The following is a description of a gene set: species: Mus musculus Cytokines mediate cell-cell communication in the immune system and represent important therapeutic targets. A myriad of studies have highlighted their central role in immune function, yet we lack a global view of the cellular responses of each immune cell type to each cytokine. To address this gap, the authors created the Immune Dictionary, a compendium of single-cell transcriptomic profiles of more than 17 immune cell types in response to each of 86 cytokines (>1,400 cytokine-cell type combinations) in mouse lymph nodes in vivo. A cytokine-centric view of the dictionary revealed that most cytokines induce highly cell-type-specific responses. For example, the inflammatory cytokine interleukin-1β induces distinct gene programmes in almost every cell type. A cell-type-centric view of the dictionary identified more than 66 cytokine-driven cellular polarization states across immune cell types, including previously uncharacterized states such as an interleukin-18-induced polyfunctional natural killer cell state. Mouse Gene Set: CUI_T_CELL_CD4_IL17B_RESPONSE_UP Genes positively differentially expressed in cell type: CD4+ T cell upon treatment with cytokine: IL-17B in mouse lymph nodes in vivo. from publication Cui A, Huang T, Li S, Ma A, Pérez JL, Sander C, Keskin DB, Wu CJ, Fraenkel E, Hacohen N (PMID 38057668), and this is the list of marker genes: Ifit1, Bst2, Ifi203, Ifi27l2a, Ms4a4b, Ly6a